Given this list of marker genes TAF1, CBX5, SETD1B, UTY, RBM15, SNRPD1, EED (NCBI Gene Id 8726), TRMT112, SNRPB, PHF20, ZNF335, KDM1A (lysine demethylase 1A), TAF6, EPOP, ERH, INO80C, E2F6, BOD1L1, TRMT11, JARID2, RBM15B, CHD8, WDR5B, TAF9, THUMPD3, SNRPE, PHF19, HCFC2, PAGR1, KDM6A, PRPF31, PRDM4, RBBP4, MTF2, C17orf49, TRMT61B, SETD1A, DYDC2, PHF1 (PHD finger protein 1), THUMPD2, TRMT10C, METTL3, CLNS1A, DPY30 (NCBI Gene Id 84661), RBBP5, RCOR1, SUZ12, ASH2L, KAT8, RUVBL2, KANSL1, DYDC1, VIRMA, TAF7, HCFC1, PELP1, PRMT1, CBLL1, RBBP7, WTAP, N6AMT1, EZH1, WDR4, SNRPD2, SNRPD3 (NCBI Gene Id 6634), KMT2A (NCBI Gene Id 79951), SENP3, RIOK1, BOD1, METTL14, WDR77, PRMT5, SIRT1, HSD17B10, KMT2B, NCOA6, SNRPG, FUT6, RAMAC, KDM6B, KMT2C, METTL4, HDAC9, RNF2, TRMT61A, MEN1 (menin 1), TAF4, PAXIP1, DNMT3L, LAS1L, METTL1, WDR82, WDR5, MGA, TEX10, SNRPF, MCRS1, ZC3H13, CXXC1, RUVBL1, RNMT, TRMT6, TRIM37, EZH2, AEBP2, KMT2D, MAX, HDAC2, here is a description of the gene set: Human Gene Set: GOCC_METHYLTRANSFERASE_COMPLEX A protein complex that possesses methyltransferase activity. studied in species Homo sapiens